Given this list of marker genes Adam30 (a disintegrin and metallopeptidase domain 30), Adam25, B4galt1, Zp2, Zp1, Hyal5, Adam2 (NCBI Gene Id 11495, a disintegrin and metallopeptidase domain 2), Zp3, Adam21, Ovgp1, here is a description of the gene set: Mouse Gene Set: REACTOME_INTERACTION_WITH_CUMULUS_CELLS_AND_THE_ZONA_PELLUCIDA studied in species Mus musculus Interaction With Cumulus Cells And The Zona Pellucida